The following is a description of a gene set: Human Gene Set: MODULE_151 studied in species Homo sapiens Genes in the cancer module 151., and this is the list of marker genes: NDUFAF7, MAPKAPK3, RRP9, DAD1, MRPL21, AP2S1, RNASEH2C, CTSC, RPS27A, RPL13A, ECI1, KPNA4, HSBP1, ATP5MF, RPS9, PSMD6, ATP5MJ, RPL39, RPL7A, UQCRH, RPS27L, RPL13, EIF3K, CDC37, RPL32, RPL4, RACK1, RPL35 (NCBI Gene Id 92393), APRT, EXOSC4, RPL10A, RCN2, TPRKB, NDUFA13, VBP1, RPS28, HINT1, ATP5F1E, STMN1, RPLP1, RPL12, ALDH9A1, RPL35A, EIF3F, BCAP31, DAP, LSM3, RPL36AL (NCBI Gene Id 93632), CDC40, RPS3, LGALS3, ATP5PF, RPL19, RPL23, GSN, GPX4, EEF1A1, RPL18, LSM5, CSNK2B, SRP9, ACADM, METAP1, CYBA, CHMP2A, EEF1G, CLEC2B, ATP6V0E1, RPS2, ATP5ME, ATP5F1B, SNRPC, GRHPR, MFSD1, RPL10, MSI1, SNRPE, GABARAPL2, COX7A2, P4HB (NCBI Gene Id 94756), CD63, EEF1D, RPL38, HIGD2A, NDUFB1, RPS16, RHOG, RPS19, RPL26 (NCBI Gene Id 6154), ZMPSTE24, ARPC3, MTPN, STAU1, UXT, RPL29, WDR83OS, RPL8, EIF3M, PRDX4, MRPS24, ZNF706, CNPY2, GPX1, UQCRB, ETFB, PSMA6, PCNA, MNDA, SNRPG, ERRFI1, EIF4B (eukaryotic translation initiation factor 4B), BST2, PSMB4, PRELID1, RPS5, FUCA1, CCNDBP1, COMT, SRSF2 (serine and arginine rich splicing factor 2), GNG10, RPS23, MRPS18B, CHPF, SNRPD2, C19orf53, UQCRQ, RPS27, ZNF525, MACROH2A1, NDUFS4, CST7, NDUFV2, B2M, TMEM59, ELOC, PSMB1, FKBP2, RPL36A, COX7C, DDX3Y, PRDX1, CLIC1, ATP5IF1, RPL21, PHB2 (NCBI Gene Id 11331), EXOSC7, NDUFA4, SPG21, CANX (NCBI Gene Id 821), RPL6, RPS20, ZNHIT1, RPL7, EDRF1, RPS21, RPS25, COX7B, ZNF451, CAPNS1, GTF2A2, PLP2, RPL18A, RBX1, SLC25A5, RB1, MYL6, RBCK1, SNRPB, SF3B5, MRPL33, ECPAS, PCBP1, STRAP, COX6B1, PTMA, IL2RG, CCT8, LDHA, ARPC2, CIAO2A, EEF2 (NCBI Gene Id 408221), COX6C, SEC61B, RAB10, BLOC1S1, RPL34, CPQ, RSL24D1, EIF3G, PYGL, ADIPOR2, EEF1B2, RPS13 (NCBI Gene Id 6207, ribosomal protein S13), NAP1L1, NDUFAB1, UQCRC2, MGST1, CNIH1 (cornichon family member 1), IMP3, RPL14, RPL9, SEC11A, MYL12B (myosin light chain 12B), RPL27, SEMG2, KRT24, RPLP0, ACTR2, SRSF7, PKM, TAF7, NDUFA1, RPE, RPL24, TPD52L2, NME4, PSMA2, NPM1, UBL5, CCT3, SNX6 (sorting nexin 6), ZFP36L1, PLTP, GABARAP, HPRT1, HLA-A, NDUFB7, CES1, NCL, PSMA4, FDPS, MAGT1, GAA, EIF3H, LYZ, RPS4X, RPS24, SOD1, RTRAF, SSBP1, CIB1, MDH1, UQCRFS1, PFN1, RPS11, TPI1, COX5B, AIF1, RAD23A, BEX1, NME2, HLA-C, ACAA1, CBX6, PPA1, DPP7, ABCC1, SNRPB2, RPS4Y1, ATP6V0B, SRGN, DYNLL1, RPL28, SDHB, APMAP, IDH3B, NSA2, ZFAND6, PIH1D1, PSMD8, TRA2B, VDAC1, HSPA8, ARPC1B, BTF3, LRPPRC, RPL27A, RPL15, LBR, RPS15A, DPY30, ATP5MC3, ARMT1, NDUFS5, RPL17, ELOB, CARD19, RPS10, FABP5, RPL23A, TMEM230, INHBB, UBA52, TIPIN, RPS3A, MB, TPSAB1, ERP29, PPIB, GYG1, PNP, XPNPEP1, NACA, RPL31, OAT, EIF3I, EIF3E, M6PR, GADD45G, PRDX6, RPSA, DHRS7, PSMD10, UCP2, IMPDH2, YWHAG, ECH1, RPL11